Given this list of marker genes Drp2, Sntb2, Sgca, Sgce, Sspn, Acta2, Sgcd, Megf6, Actb, Dtnb (NCBI Gene Id 13528), Sgcz, Acta1, Actc1, Sntg2, Agrn (agrin), Snta1, Dmd, Sgcb, Lama4, Actg1, Sntb1, Dag1, Sgcg, Actg2, Utrn, Dtna, here is a description of the gene set: studied in species Mus musculus Mouse Gene Set: REACTOME_FORMATION_OF_THE_DYSTROPHIN_GLYCOPROTEIN_COMPLEX_DGC Formation of the dystrophin-glycoprotein complex (DGC)